Given this list of marker genes SMN1, SPTLC1, RYR1, ADSS1, ANO5, here is a description of the gene set: Muscular atrophy involving the quadriceps muscle. species: Homo sapiens Human Gene Set: HP_QUADRICEPS_MUSCLE_ATROPHY Quadriceps muscle atrophy